The following is a description of a gene set: Human Gene Set: HP_ABNORMAL_HAIR_QUANTITY Abnormal hair quantity species: Homo sapiens An abnormal amount of hair., and this is the list of marker genes: KMT2A, SUZ12, BPTF, CDON, POLD3, BRF1, TREX1, VAMP7, SHROOM4, TALDO1, CWF19L1, PGM2L1, LIFR, SF3B4, LAMB3, MT-TF, CERS3, CDH11, SOS1, ANKRD11, BTD, FGF17, ARX, PEX6, NFKB2, KATNB1, SATB2, GJA5 (NCBI Gene Id 2702), UGDH, VPS37A, FLII, PPP1R15B, PRKCD, COPB1, ATR, DMXL2, EDN3, WNT10A, LHB, KRT5, ALK, KCNH1, GABRA3, BLM, DDB1, DNASE1, CNTNAP2 (NCBI Gene Id 26047), CANT1, PSMB10, TACR3, LEMD3, MEN1, KDSR, LPAR6, DPH5, TERT, SPP1, KIT, AHDC1, HSPA9, GNS, ARMC5, IGF1R, DEAF1, WWOX, IFT172, FOXL2, LMNB2, AFF4, IFT43, KDF1 (NCBI Gene Id 126695), ADA, ZNF292 (NCBI Gene Id 23036), FOXE1, EDNRA, ODC1, PLAAT3, BNC1, GLI1, TMCO1, MKS1, MESD, COX5A, KRT71, PRKACB, SCAPER, LAMC2, MAP2K1, MTX2, RBM28, IL2RA, NMNAT1, ASH1L, ATP7A, IL10, ST14, ZSWIM7, RAF1, GLB1, ABHD5, AIP, CASP2, NKX6-2, TRIM32, MT-ND5, TBC1D20 (TBC1 domain family member 20), ALX1, KRT74, ATP2B1, KIAA0753, FIG4, RAC1, CUL4B, POR, SMARCB1, JAZF1, EBF3, GJB3, GJA1, NSRP1, NAGLU, SLC7A7, LTBP3, DNAJC21, DYM, ARL3, SOX9, GNA14, PPP1R21, TFE3, EXT2, H3-3B, TBX15, TLK2, PIGL, NSMF, PACS2, HID1, TNIP1, NTRK1, CHRNA7, CAV1, DKC1, UBAP2L, CACNA1G, PLK4, XPA, TOE1, IRF6, CEP152, POLR1B, TRIO, C3orf52, EMC10, DLL4, TBX3, DLX4, KRT86, FGFR2, MT-ND4, SKI, RAB18, NIPBL, CHMP1A, TRIM8, PSMB8, TGM1, DVL3, BBS2, MBTPS2, ABCD1, SNX14, IFT122 (NCBI Gene Id 55764), TOMM7, DVL1, TWIST1, CYP11B1, MITF, MED25, PIK3R1, BCORL1, DNMT3A, NDST1, SPRY4, KDM5C, KRT6A, ARID1B, HPGD, RRAS, P4HA2, CDH2, AP1B1, CNOT2, RAB3GAP1, ANAPC1, DNA2, CTSC, CEP57, CHD7, LSS, BCL11B, NANS, ACTB, EDAR, TAF6, TUBB, RRAS2, PRKAR1A, WAC, PADI3, CERT1, MAPK1, IGHG1, SLITRK1, IRX5, CFAP418, SDCCAG8, IKBKG, KANSL1, FREM1, CTC1, SRA1, SKIC3, C18orf32, LZTR1, SMARCD1, PAX3, SLC25A24, BAP1, ABCA5, PAPSS2, TWIST2, H6PD, ALG9, NSDHL, WDR81, ATP6V1B2, HRAS, GJB6, MAB21L1, PNPLA6, NIPAL4, CDH3, TRAPPC10, MPLKIP, DUSP6, SREBF1, BCS1L, RAB3GAP2, KRT10, NEU1, SCN4A, NR5A1 (nuclear receptor subfamily 5 group A member 1), GJB2, NDUFAF6, NEK1, PLAA, ARSB, FZD2, CHSY1, DHX30, CASR, BSCL2, TRPS1, TAF1, SMARCD2, FCGR3B, ASXL3 (NCBI Gene Id 80816), KIFBP, WDR19, ROR2 (NCBI Gene Id 621), NR3C1, WLS, OTUD5, BMP15, RBBP8, CWC27, ATRIP, RIT1, FGFR1, MDM2, MAP1B, SDR9C7, AARS1, SOX10, ZIC2, KISS1 (KiSS-1 metastasis suppressor), FAS, ZNF699, IFT140, SETD5, ORC6, MANF, BRAF, MOGS, SMC3, AMMECR1, PDCD1, HNRNPU, RNF125, RHOA, SMAD4, CDH23, HIVEP2, GABRD, ERCC3, NOP10, CTNND1, KCNK4, ADAMTS2, COL18A1, CYP17A1, CST6, WRN (NCBI Gene Id 7486), CLDN1, DSG4, KRT17, GATA1, PHF8, RNF113A, MBD5, CDKL5, AGPAT2, MARS1, DOCK6, WDR26, SEMA3E, MT-ND6, MAPK8IP3, ZNRF3, SETBP1, PLCB4, WDPCP, ZMPSTE24, BCAS3, TUBGCP2, NRAS, NOTCH2, STAT4, ALDH6A1, SRD5A3, SAT1, IQSEC2, HLA-DRA, NFKB1, APOE, NECTIN1, MED13, CREBBP, PRKD1, CSTB, DSP, POC1A, PTPN22, LTV1, IL1RAPL1, TTC7A, WARS1, KIF26A, MMP2, EIF4A2, ADAMTS3, CLCN3, COL17A1, PHIP, BLK, LRP1, PRKG2, HPD, DOCK7, HR, IFT74, WASHC4, CHD5, LIPN, APCDD1, DYNC2LI1 (NCBI Gene Id 51626), PRIM1, KLF13, USP8, HDAC8, RBPJ, ARHGAP31, COL3A1, CSGALNACT1, UBE2L3, FCGR2B, CPOX, DCLRE1B, SLC1A4, ETS1, FGF3, POLR1C, HRURF, IL7R, PDE11A, EOGT, B3GALT6, PERP, MAN2B1, WNT5A, SOX4, ALOXE3, MT-TQ, RAB34, NF1, MED27, MRAS, BANF1, SNAI2, GATA4, NFKBIA, PDPN, PIGU, FLNA, CDKN2A, HEPHL1, NXN, RAD21, THUMPD1, BBS9, TMEM94, MEG3, NUP107, ALMS1, STUB1, GJB4, PTPN11, PPP2R3C, TRPV3, RPL10, MED12, GPC4, SEC23A, SMARCE1, CDH1, FBXL4, PROKR2, TTI2, XYLT1, LZTFL1, UBE4B, CTLA4, KLHL24, POP1 (POP1 homolog, ribonuclease P/MRP subunit, NCBI Gene Id 23044), UQCC2, NSUN2, PACS1, HLA-DRB1, MAP2K2, BGN, TRAC, TAF4, MT-TW, ERCC8, FBXO31, DDB2, TRMT1, XRCC4, CRELD1, TNFAIP3, SETD2, ASXL1, RIPK4, EZH2, DPH1, PTCH1, KISS1R (KISS1 receptor), NECTIN4, RASA2, KDM1A, CACNA1C, COL11A1, DPF2, KRAS, ACD (NCBI Gene Id 82538), TRAPPC9, GPC3, ZNF711, ARID1A, DOLK, TSPEAR, ITGAM, GTPBP2, RTEL1, TARS1, HTRA1 (NCBI Gene Id 5654), BICRA, ARL6, KCNMA1, TINF2, HDAC4, ZEB2, MGP, FBXO11, NDUFA12, ASPRV1, ERCC2, DCAF17, SOX5, EDNRB, TBCD, COL7A1, WDR35, FBXO28, TAC3, NHLH2, PSMD12, TP63, INSR, TASP1, BMP2, PEX1, PARN, SPOP, PRMT7, FOS, NPHP1, ITGA3, SKIC2, OFD1, TFAP2A, CBS, VDR, UBE2A, ITGB6, ECM1, RIN2, MT-CO3, NEPRO, KMT2B, TOGARAM1, IPO8, PRKCZ, GSN, SOS2, ATP6V1A, FOSL2, HMGA2, PCNT, UROD, IRAK1, CCDC28B, CTCF, ZPR1, BBS1, TSR2, TCOF1, SLC32A1, AXL, FRAS1, GLI3, RECQL4, CDSN, USB1, ABCC9, ZNF407, PQBP1, KCNJ8, KDM4B, MMP23B, C4A, GNAS, SOX6, CRIPT (CXXC repeat containing interactor of PDZ3 domain), KRT85, RNU12 (RNA, U12 small nuclear), SLC25A12, FOXP3, CDK10, FHL1, KCNAB2, DLX3, IRF5, PUF60, PRPS1, FLI1, SLC4A10, COG7, MMP14, FUT8, CYP4F22, PPOX (protoporphyrinogen oxidase), IFT52, SMC1A, NPM1, GNRH1, PSMC3IP, CCDC141, SPTBN1, CDC42BPB, SLC27A4, CNP, MT-TS2, LRPPRC, AXIN2, WBP11, PROK2, KRT81, EP300, EDARADD, MECP2, SMO, ZNF341, MAPKAPK5, SPIDR, TGM3, NSD1, EHMT1, APC2, FOXN1, TBCK, UBE3B, MT-CO2, CARS1, KREMEN1, XPC, MAPRE2, CDK5, VPS33A, PRDM16, BBS5, MAF, FTL, SMARCA4, BTNL2, WRAP53, CLMP, SUCLA2, ATP6V1E1, GNPTAB, CTNNB1, CENPE, TYMS, UBA2, SMPD4, MKKS, RAG2, ALOX12B, KAT6B, MSX1, MT-CO1, SMARCA2, ZBTB20, DPAGT1, HFE (homeostatic iron regulator), EXOSC2, DSG1, POLR3A, NBN, UBR1, LUZP1, SMCHD1, AFG2A, B4GALT7, ATRX, GTF2E2, SMS, FMR1, SHOC2, TRAF6, CEP290, RERE, VPS13B (NCBI Gene Id 54990), CR2, BRD4, SOX11, NUP85, SLC29A3, AKT1, IL6ST, IFT27, BANK1, MT-TH, STAG1 (NCBI Gene Id 10274), PI4KA, FSHB, NUS1, CAMK2B, CYB5A, UQCRFS1, POLR1D, CD28, HLA-B, GNB2, BBS12, ERCC5, GNA11, MT-TL1 (mitochondrially encoded tRNA-Leu (UUA/G) 1), COG4, ERLIN2, MCCC2, TTC5, WNT10B (NCBI Gene Id 82499), ADAT3, DLK1, ALDH18A1, MASP1, MT-ND1, NDUFA6, KRT14, PSMC3, SPEN, VAC14, SRCAP, WT1, RMRP, BMP1, SPRTN, CBL, SLC39A4, NFIX, TNFRSF1B, EPS8L3, HSPG2, SNRPE, HS6ST1, UROS, KCNN3, TERC, PEX7 (NCBI Gene Id 5191), KDM6A, GATAD2B, SASH1, SCLT1, KIAA0319L, AFF3, TNFSF4, HECTD4, KANK2, SULT2B1, FRMD4A, PPARG, MRPS22, LAMA3, SPINK5, CLP1, RTL1, WDR11, LORICRIN, SOX18, ERCC4, PHGDH, ZMYND11, PLEC (plectin), PIGN, PEPD, OCRL, PCGF2, FGF10, PUM1, KNSTRN, HNRNPR, HSD3B2, CCDC47, CDC42, ARID2, UGP2 (NCBI Gene Id 7360), POLR3H, HEATR3 (NCBI Gene Id 55027), ATP6V0A2, IDUA, AIMP2 (aminoacyl tRNA synthetase complex interacting multifunctional protein 2), USP48 (NCBI Gene Id 84845), EVC, NHP2, JARID2, DPH2, ALX4, PNPLA1, KRT83, SRY (NCBI Gene Id 6995), LIG4, B3GLCT, KRT16, BBIP1, EXT1, BBS7, RUSC2, KCTD1, PKP1, GNE, HLA-DQB1, GUSB, CSNK2A1, FGF8, CAVIN1, CAPN15, ESCO2 (NCBI Gene Id 5951), MAP3K1, SGSH, POGZ, USP9X, OGT, FEZF1, ITGB4, ESAM, GJA8, CEP19, PCDHGC4, LMNA, HGSNAT, BRCA1, EVC2, PHF6, EDA2R, UBR7, TLR7, TTC8, TRMT10A, LIPH, BBS4, ASL, CCBE1, PORCN, SPRED2, C4B, BBS10, MAP3K7, GNRHR, DCLRE1C, HOXC13, PYCR1, ANTXR1, TMEM147, UFC1, MGAT2, RAI1, KRT6B, AEBP1, STING1, IDS, SMARCC2, RPS23, DSC3, EDA, FAT4, PIK3CD, ABCA12, EBP, AHSG, KMT2D, ERCC6, PRKACA, PDGFRB, PPP1CB, RAG1, JUP, CASZ1, TMPRSS6, PXK, SLC30A2, CHD6, MSH4, AIRE, KRT25, EIF5A, ASXL2, DHX37, ZFPM2, NR0B1 (NCBI Gene Id 8238), HLA-DQA1, TRAIP, PTDSS1, RNU4ATAC, SLCO2A1, WNT4 (Wnt family member 4), RPL21, CKAP2L (NCBI Gene Id 150468), FRA10AC1, RECQL, ANOS1, AR, ELMO2, NUDT2, ZFX, CYP19A1, NOTCH1, KNL1, PRR12, GPR101, IL2RG, ACVR1, ADNP, FSHR, BTK, GTF2H5, TP53, FAM111B, PPP1R13L, HLCS, MSTO1